Given this list of marker genes SULT2B1, ATP1A3, GPER1, NR3C1, ATP1A2, ATP1A1, here is a description of the gene set: studied in species Homo sapiens Binding to a steroid hormone. Human Gene Set: GOMF_STEROID_HORMONE_BINDING